The following is a description of a gene set: species: Homo sapiens Human Gene Set: MIR6739_3P from publication Chen Y, Wang X (PMID 31504780) Genes predicted to be targets of miRBase v22 microRNA hsa-miR-6739-3p in miRDB v6.0 with MirTarget v4 prediction scores > 80 (high confidence targets)., and this is the list of marker genes: TCF12, TRIM66, SPAG9, ZFP69, EFCAB5, SSUH2, ANKRD50, ZFYVE28, DIP2C, POU4F1, PDPK1, MXI1, KCNJ13 (potassium inwardly rectifying channel subfamily J member 13), PTPMT1, GREM2, SERINC4, XKR5, ITPKB, GOLPH3, RBM47, SCIMP, RIMS1, NLK, C8orf44-SGK3, CLCN2, CASZ1, GRIK5, QKI, CACNG2, PREX2, MATR3, ZBTB20, DERL1, DISC1 (DISC1 scaffold protein), LARS1, NOX3, ULK2 (unc-51 like autophagy activating kinase 2), C1orf141, GPM6B, SIPA1L2, SEC23A, SLC25A31, ELAVL4, RLF, NOG, NKAPD1, FZD8, TRIM51, COG2 (component of oligomeric golgi complex 2), ERCC6L2, CRISPLD2, ZNF470, YWHAZ, ZNF385B (zinc finger protein 385B), RBPJ, SLC10A7, MAN1A2, BMPR2, RAB33B, GABRG1, NCOA2, CEPT1, EIF4H, NXT2, AKAP1, IRS1, CHIC1, CCL28, DSC3, HIVEP2, EIF4G3, MEF2A, MAP3K2, SPOP, ARMC8, ZIC5, MMGT1, SLC4A4, UBE3A, KLHL20, CSNK2A1, DNALI1, CNGB1, SLCO4C1, CPNE8, POC1B, EIF5A2, IGFBP4, SEMA3D, MEST, HOXC4, TOP1, NAALADL2, DLG3, AKAP6, INSIG2, ARHGEF26, HMGB3, SETX, NR6A1, ZBTB10, PABIR1, GATA6, NOSIP, HNRNPD, KIT, TASOR, NBEA, TNPO3, CENPM, NOTCH2NLA, DMXL1, CCDC181, LPAR4, IFT80, XKR6, CAST, LRAT, ZC3H14, SGK3, SOCS5, UFM1, PTP4A2, ZNF831, CREBZF, CYS1, SERAC1, CNOT11, PLEKHA3, BBOF1, DLG2, RUNX2, PAG1, TENT2, CRYBG3 (crystallin beta-gamma domain containing 3), EMB, KLF4, KCNAB1, ZFP36L2, BCL6, SETBP1, SULF1, YOD1, ELK4, TSPAN2, TSC1, CA8, SOX14, MID2, RHOJ, CCNY, BCL11B, CCNDBP1, ADCY9, SYTL5, CCDC6, EDIL3, MBNL1, ADGRL1, ITPR2, AIRIM, EIF2S1, GPHN (gephyrin), ABHD5, CYP7B1, MB21D2, UST, COL4A3, BRINP1, PDK3, MBNL3, DIRAS2, DNAL1, LRIT3, PRLR, PBRM1 (polybromo 1), MED31, ARID2, ERBB4 (erb-b2 receptor tyrosine kinase 4), FOXF1, PDE10A, ATXN7, PAQR3, ZNF704, THEMIS, PDE4D, TCAIM, SPOCK1, LDHB, AEBP2, OPA1, HLCS, KLF5, DUSP6